Given this list of marker genes Pdgfa, Pdgfra, Ceacam1, Ubash3b, Gp5, Sh2b3, Prkg1, Cd9 (CD9 antigen), Apoe, Prkcd, Pdgfb, Tmx1, Adamts18, Alox12, C1qtnf1, Serpine2, here is a description of the gene set: Any process that decreases the rate or frequency of platelet activation. Platelet activation is a series of progressive, overlapping events triggered by exposure of the platelets to subendothelial tissue. Mouse Gene Set: GOBP_NEGATIVE_REGULATION_OF_PLATELET_ACTIVATION studied in species Mus musculus